Given this list of marker genes Apc, Ppp2r1a, Ppp2r5b, Frat1, Ctnnb1, Ppp2r5a, Ppp2r5e, Frat2, Ppp2cb, Gsk3b, Ppp2r5c, Axin1, Ppp2r1b, Ppp2r5d, Csnk1a1, Amer1, Ppp2ca, here is a description of the gene set: Beta-catenin phosphorylation cascade species: Mus musculus Mouse Gene Set: REACTOME_BETA_CATENIN_PHOSPHORYLATION_CASCADE